The following is a description of a gene set: Members of the RAS gene family were the first oncogenes to be identified, and mutations in RAS are present in ~20-30% of human cancers. Mutations in the KRAS gene are the most prevalent, and are found with high frequency in colorectal cancer, non-small cell lung cancer and pancreatic cancer, among others. The reasons for the lower prevalence of HRAS and NRAS mutations in human cancers are not fully understood, but may reflect gene-specific functions as well as differential codon usage and spatio-temporal regulation. Activating RAS mutations contribute to cellular proliferation, transformation and survival by activating the MAPK signaling pathway, the AKT pathway and the RAL GDS pathway, among others.<br><br>Although the frequency and distribution varies between RAS genes and cancer types, the vast majority of activating RAS mutations occur at one of three residues - G12, G13 and Q61. Mutations at these sites favour the RAS:GTP bound form and yield constitutively active versions of the protein. Reactome Pathway: Signaling by RAS mutants studied in species Homo sapiens part of: Oncogenic MAPK signaling, and this is the list of marker genes: MARK3, CNKSR1, JAK2, MAP2K2, BRAP, FGA, ITGB3, ACTG1, FGG, HRAS, MAPK3 (mitogen-activated protein kinase 3), CALM1, FN1, SRC, MAP3K11, ARRB1, RAP1A, ARRB2, NRAS, PHB1, APBB1IP (NCBI Gene Id 54518), VCL, MAP2K1, CAMK2B, ITGA2B, CAMK2A, CNKSR2, MAPK1, CAMK2D, CAMK2G, YWHAB, CSK, KSR2, ACTB, RAF1, BRAF, KSR1, IQGAP1, PEBP1, FGB (fibrinogen beta chain), TLN1, RAP1B (RAP1B, member of RAS oncogene family), VWF, ARAF, KRAS